The following is a description of a gene set: part of: Post-translational protein modification Reactome Pathway: Deubiquitination This event has been computationally inferred from an event that has been demonstrated in another species.<p>The inference is based on the homology mapping from PANTHER. Briefly, reactions for which all involved PhysicalEntities (in input, output and catalyst) have a mapped orthologue/paralogue (for complexes at least 75% of components must have a mapping) are inferred to the other species. species: Mus musculus electronically inferred by orthology from the curated human pathway, and this is the list of marker genes: Tfpt, Usp28, Psma5, Psmd12, Becn1, Axin2, H2ac25, Asxl2, Josd1, Psmd1, Brcc3, Ube2d1, Ep300, Ccna1, Prkn, H2ac23, Usp22, Rnf123 (ring finger protein 123), Trp53, H2ac8, Myc, Kdm1b, Nedd8, Usp3, Mysm1, Ubb, Il33, Mul1, Psmd6, Taf10, Psmd13, Usp21, Usp26, Brca1, Usp17lb, Fkbp8, Psma7, Yy1, Tab1, H2ac7, Psmc2, Axin1, Usp42, Senp8, Bard1, Wdr48, Psmb4, Psmd7, Otud7a, Usp19, Nlrp3, Snx3, Cyld, Suds3, Foxo4, Cdk1, Rnf128, Usp12, Ptrh2, Usp17lc, Nfkbia, Ino80b, Rigi, Psma1, Psma2, Birc3, Wdr20, Esr1, Psmc1, Smad1, Ar, Psma6, H2ac12, Tnfaip3, H2ac6, Psmc6, Usp5, Psma4, Rps27a, Usp4, H2ac4, Psmb6, Otud3, Psmc3, Vcpip1, Ufd1, Usp37, Tnip3, Traf3, Tomm20, Usp17ld, Arrb2, Vdac2, Otub1, Psmb7, Hif1a, Smad3, Hcfc1, Usp44, Usp25, H2ac20, Psmc5 (NCBI Gene Id 19184), Babam1, Foxk1, Smad7, Usp17la, H2ac15, Gata3 (GATA binding protein 3), Vcp, Psmb5, Ino80c, Usp47, H2ac19, Usp29, Vdac3, Josd2, Nfrkb, Smurf2, Taf9b, H2ac13, Vdac1, Tnip1, Uchl3, H2ac11, Ifih1, H2ac24, H2ac1, H2ac22 (H2A clustered histone 22), Asxl1, H2ac10, Tnks2, Rnf146, Psma3, Psmc4, Stam